The following is a description of a gene set: species: Homo sapiens Genes down-regulated in comparison of untreated macrophages versus those cultured with M-CSF. Gene expression analysis of freshly isolated CD14+ human monocytes and monocytes cultured in the presence or absence of interferon (IFN) -gamma for 24 h and then stimulated with Pam3Cys, a Toll-like receptor (TLR) 2 ligand, for 6 h. Results provide insight into mechanisms by which IFN-gamma reprograms early macrophage differentiation and subsequent response to TLR ligands. Human Gene Set: GSE11864_UNTREATED_VS_CSF1_IN_MAC_DN from publication Hu X, Chung AY, Wu I, Foldi J, Chen J, Ji JD, Tateya T, Kang YJ, Han J, Gessler M, Kageyama R, Ivashkiv LB (PMID 18976936), and this is the list of marker genes: SIGLEC9, ADAM10, ARAP1, HS3ST1 (heparan sulfate-glucosamine 3-sulfotransferase 1), P4HA2, BCAR3, SNAPIN, PI4K2A, COCH, TUBA1B, DDX23, KDM2B, NQO1, GK3, ORMDL2, LIG1, HTRA2, ETFBKMT, STXBP3, ZBTB33, KCTD5, THEMIS, PNMA1, PITHD1, PDCD7, KCTD7, LINC00324, MBLAC2, ZNF248, IMMP1L, DAXX, ZNF571, TINF2, ANKRD29, STARD13, OXNAD1, PIN4 (NCBI Gene Id 5303), MRPL27, USP19, CAB39L, ZNF382, CKAP5, NUP43, PRKCI, PGLYRP3, TMEM218, ARL15, TRAM1, HBP1, ZNF19, ZNF816, LFNG, MIR663AHG, SLC30A1, PTER (phosphotriesterase related), PRKAR2A, MYDGF, RBSN, HIRIP3, MED14, HEBP1, SLC2A13, SLAMF7, FJX1, RNF182, ACOT4, NTPCR, CCM2, SPOP, TBL2, BMS1P2, SIGLEC1, TLR8, MED28, DLEU2, CXCL3, RB1, NAA30, LXN, CRYZ (crystallin zeta, NCBI Gene Id 1429), BORA, NUBP1, GEM, ATP10D, PEX14, DNPH1, UNC50, EIF2B5, HCCS, KDM5D, ZNF701, GOSR1, ELP3, ABCC5, CANX, CNRIP1, ZFP37, TEX56P, TBC1D8B, GLB1, POGZ, IFT122, ME3, PUM2, TIMM17A, GIGYF2, GMPPB, INTS13, HSPBAP1, FNTB, LINC00639, IPO9, CLCN5, ZNF175, HECTD3, CCL24, ZMYND15, RP2, C1orf122, ZNF416, MCEE, MTG1, LIN9, TBC1D24, EMC2, YARS2, AIFM1, MTX2, ADORA3, ZNF407, GPR157, RDX, C9orf40, JPT2, MYL6, LINC00921, TPRA1, ZNRF2, IL1RL2, RACGAP1, SLFN11, ID3, PDE2A, CASC3, GABRG3, HAVCR2, SPDL1, HFE, USP51, PUS3 (NCBI Gene Id 83480), REEP5, DPM3, BTD, ZC3H6, GTF2IRD1, ZNF224, CPTP, KLHL9, SEPTIN7, MEGF8, NOSIP, BEST1 (bestrophin 1), DIRC3, PARG, PILRA, CD72, B3GALT5-AS1, PPP1R21, MRPS28, APOC2, ISX, WIPF2, MTMR10, ZBTB3, DPY19L4, SPTAN1, LNX2, JADE3, SACS, NAPEPLD, ZNF322, EBAG9, WIPF3 (NCBI Gene Id 648464), GLA, DNAL1, CHMP4A, NHSL2, EPC2, CALHM2, UQCR10, CYP2B6, CDCA7L, TEX264 (testis expressed 264, ER-phagy receptor), VEZT (NCBI Gene Id 55591), DHRSX, VPS26C, HSDL1